Given this list of marker genes APOE, GUCA2B, SCT, ADRB3 (adrenoceptor beta 3), SORL1, STK39, CNTN2, MAPK14, ADRB2, PRLH, GFRAL, SLC25A25, BMP8A, ADRB1, RASAL2, LEP, GDF15, UCP1, VGF, TRPV1, GDF3, SCTR, OMA1, ACVR1C, SGIP1, RMI1, LIPA, WNK4, C1QTNF4, TBL1XR1, NMUR2, COL6A1, PPARGC1A, TRPV4, PCSK1N, APPL2, here is a description of the gene set: The physiological process in which dietary excess is sensed by the central nervous system, resulting in a reduction in food intake and increased energy expenditure. species: Homo sapiens Human Gene Set: GOBP_RESPONSE_TO_DIETARY_EXCESS